Given this list of marker genes FIG4, PITX1, EOGT, DYNC2H1, XRCC2, FGFR2, GJA1, TRIO (NCBI Gene Id 7204), NSDHL, LMNA, ATP6V1B2, VAC14, LONP1 (NCBI Gene Id 9361), FANCD2, MEGF8, SHH, LMBR1 (NCBI Gene Id 85501), IFT140, BMPR1B, GLI3, CHD7, KCNN3, TBX5, ATP7A, GDF5, here is a description of the gene set: species: Homo sapiens Human Gene Set: HP_APLASIA_INVOLVING_BONES_OF_THE_EXTREMITIES Aplasia involving bones of the extremities